The following is a description of a gene set: Anatomic features of unbalanced atrioventricular septal defect (AVSD) include varying amounts of ventricular hypoplasia, as well as malalignment of the atrioventricular junction. In complete AVSD, the common AV valve can be situated either equally over the right and left ventricles (balanced) or unequally over the ventricles (unbalanced). Human Gene Set: HP_UNBALANCED_ATRIOVENTRICULAR_CANAL_DEFECT species: Homo sapiens Unbalanced atrioventricular canal defect, and this is the list of marker genes: SMAD2, CFAP53 (cilia and flagella associated protein 53), IFT56, DNAH9, PLXND1 (plexin D1), PKD1L1